Given this list of marker genes SRF (serum response factor), MAPK3, ARF4, PTPN11, ARL3 (NCBI Gene Id 403), MAP2K3, MAPK8IP3, ARL4A, GNA12, DIRAS1, CTNNAL1 (NCBI Gene Id 8727), CSPG4, IGHM, TRIB3, ARFIP2, DAB1, BAIAP2 (NCBI Gene Id 10458), RABL6, EGF, SPRED1, ERAL1, here is a description of the gene set: from publication Ouyang X, Jessen WJ, Al-Ahmadie H, Serio AM, Lin Y, Shih WJ, Reuter VE, Scardino PT, Shen MM, Aronow BJ, Vickers AJ, Gerald WL, Abate-Shen C (PMID 18381418) Human Gene Set: OUYANG_PROSTATE_CANCER_PROGRESSION_DN studied in species Mus musculus To identify biomarkers that discriminate the aggressive forms of prostate cancer, we performed gene expression profiling of prostate tumors using a genetically engineered mouse model that recapitulates the stages of human prostate cancer, namely Nkx3.1; Pten mutant mice. We observed a significant deregulation of the epidermal growth factor and mitogen-activated protein kinase (MAPK) signaling pathways, as well as their major downstream effectors--the activator protein-1 transcription factors c-Fos and c-Jun. Forced expression of c-Fos and c-Jun in prostate cancer cells promotes tumorigenicity and results in activation of extracellular signal-regulated kinase (Erk) MAPK signaling. In human prostate cancer, up-regulation of c-Fos and c-Jun proteins occurs in advanced disease and is correlated with Erk MAPK pathway activation, whereas high levels of c-Jun expression are associated with disease recurrence. Our analyses reveal a hitherto unappreciated role for AP-1 transcription factors in prostate cancer progression and identify c-Jun as a marker of high-risk prostate cancer. This study provides a striking example of how accurate mouse models can provide insights on molecular processes involved in progression and recurrence of human cancer. Genes down-regulated during prostate cancer progression in mice heterozygotic for both NKX3.1 and PTEN.